Given this list of marker genes MICU1, MSTO1, NDUFA4, SCO2, TCAP, POLG, MLIP, CAPN3, ASCC1, NEFH, CRYAB, TNNC2, HPDL, SYNE1, KIF5A, COL6A2, ADGRG6, MYL2, ANO5, GIPC1, ANXA11, YME1L1, UNC45B, ALG2, CASQ1, CCDC174, CACNA1S, JAG2, MYL1, LMNA, MTM1, DPM3 (NCBI Gene Id 54344), DNAJB6, MYH14, PPARG, MYOT, AIFM1, KBTBD13, TPM2, NEB, RILPL1, KLHL41, COQ7, NOTCH2NLC, CHRNB1, DAG1, FHL1, FKTN, CLCN6 (NCBI Gene Id 1185), CAV3, CTBP1, TBCK (TBC1 domain containing kinase), TRIM32, TRIP4 (NCBI Gene Id 9325), GNE, LYRM4, MEGF10, COL6A1, COL13A1, POMGNT1, SELENON, ACTA1, SGCA, BVES, AHCY, TPM3 (NCBI Gene Id 91191), AARS2, VCP, MATR3, HNRNPA2B1, POMT2, ORAI1, MIPEP, ITGA7, PLEC, SCN4A, TNNT1, MFN2, TOR1AIP1, RYR3, CAVIN1, COL6A3, DYSF, POMT1, PFKM, TWNK, POPDC3, VRK1, NEK9, SGCG, GARS1, SYNE2, ALDOA, TTN, CFL2, TAMM41, LAMA2, ACTN2 (NCBI Gene Id 88), MYH2, SYT2, SLC25A12, DMD, KY, OPA1, SMN1, SQSTM1, ISCU, SMPX, MB, SUCLG1, MYPN, COL12A1, RYR1, LRP12, STIM1, MAP3K20, OBSCN, STAC3, HNRNPA1, LMOD3, SGCB, TMEM43, here is a description of the gene set: Abnormality of skeletal muscle fiber size Any abnormality of the size of the skeletal muscle cell. species: Homo sapiens Human Gene Set: HP_ABNORMALITY_OF_SKELETAL_MUSCLE_FIBER_SIZE